The following is a description of a gene set: species: Homo sapiens Protein complex forming portion of the radial spoke that is orthogonal to the elongated stalk and which projects towards the central pair of microtubules within the ciliary or flagellum axoneme. Human Gene Set: GOCC_RADIAL_SPOKE_HEAD, and this is the list of marker genes: RSPH3, RSPH6A (radial spoke head 6 homolog A), RSPH9, RSPH4A, RSPH1